Given this list of marker genes Kynu, Kmo, Kyat1, Kyat3, Aldh8a1, here is a description of the gene set: Mouse Gene Set: GOBP_L_KYNURENINE_METABOLIC_PROCESS studied in species Mus musculus The chemical reactions and pathways involving L-kynurenine, the L-enantiomer of the amino acid kynurenine (3-(2-aminobenzoyl)-alanine).